The following is a description of a gene set: studied in species Homo sapiens Human Gene Set: GOBP_EYE_MORPHOGENESIS The process in which the anatomical structures of the eye are generated and organized., and this is the list of marker genes: COL8A2, CRB1, FOXE3, CDON, SOX8, PPP2R3A, ATP8A2, SDK1, MYO7A, FBN2, MFAP5 (microfibril associated protein 5), COL5A1, IHH, FOXN4, IRX5, NKD1, CEP290, RP1, RPGRIP1, NTRK2, CRB2, TFAP2B, GDF11, JAG1, RARB, KDM2B, BCL2, BMP4, USH1C, COL5A2, WNT16, SOX4, CALB1, VSX2, MFAP2, FGF2, FZD5, NRL, LRP5, RORB, RARG, YY1, SOX9, NF1, AQP1, SHROOM2, SKI, STAU2, HIF1A, SIX3, FBN1, PITX2, ATF4, TBX2, RPGRIP1L, LHX1 (LIM homeobox 1), EPHB2 (EPH receptor B2), GNGT1, MEGF11, NR2E3, MFSD2A, RING1, NIPBL, TSPAN12, ALDH1A3, TMEM215, RBP4, PRDM1, SOX11, EFEMP1, ABI2, IMPG2, BAK1, NECTIN3, PTF1A, HIPK2, EPHB1, FJX1, THRB, PRKCI, PROM1, EPHA2, TDRD7, AGTPBP1, DIO3, FSCN2, WNT2, PHACTR4, PROX1, CNTF, KDR, CRYGB, BAX, MEIS1, BMP7, WNT2B, THY1, TSKU, HIPK1, GNAT1, RPGR (NCBI Gene Id 6110), CRYAA, FASLG, POC5, ZHX2, CITED2, CTNNB1 (NCBI Gene Id 1499), CABP4, PDE6C (phosphodiesterase 6C), AHI1, FAT3, DLL1, FAT1, TENM3, RAB37, RDH13, PTPRM, IFT172, TTC8, NAGLU, FOXF2, NDP, GNAT2, NOTCH2, TULP1, FOXL2, STAT3, VAX2, DZANK1, PAX2, MFRP, SLC1A1, BCAR3, SOX1, TBC1D20, FRS2, SP3, BBS4 (Bardet-Biedl syndrome 4), VSX1, VEGFA, COL8A1, TFAP2A, SDK2, LCTL, ZEB1, RHO, IFT122, PITX3, WNT9A, BBS10, SOX12 (SRY-box transcription factor 12), DSCAM, ROM1, C12orf57, RS1, WNT5A, MFN2 (NCBI Gene Id 9927), GLI3, STRA6, OLFM3, ARL6, TH, NECTIN1, SAMD11, ADAMTS9, MAN2A1, SAMD7 (NCBI Gene Id 344658), HMGN1, PAX6, NOTCH1, TWIST1 (NCBI Gene Id 7967), AQP5, LARGE1, HCN1